The following is a description of a gene set: Mouse Gene Set: THEODOROU_MAMMARY_TUMORIGENESIS from publication Theodorou V, Kimm MA, Boer M, Wessels L, Theelen W, Jonkers J, Hilkens J (PMID 17468756) We performed a high-throughput retroviral insertional mutagenesis screen in mouse mammary tumor virus (MMTV)-induced mammary tumors and identified 33 common insertion sites, of which genes were previously not known to be associated with mammary cancer and 13 had not previously been linked to cancer in general. Although members of the Wnt and fibroblast growth factors (Fgf) families were frequently tagged, our exhaustive screening for MMTV insertion sites uncovered a new repertoire of candidate breast cancer oncogenes. We validated one of these genes, Rspo3, as an oncogene by overexpression in a p53-deficient mammary epithelial cell line. The human orthologs of the candidate oncogenes were frequently deregulated in human breast cancers and associated with several tumor parameters. Computational analysis of all MMTV-tagged genes uncovered specific gene families not previously associated with cancer and showed a significant overrepresentation of protein domains and signaling pathways mainly associated with development and growth factor signaling. Comparison of all tagged genes in MMTV and Moloney murine leukemia virus-induced malignancies showed that both viruses target mostly different genes that act predominantly in distinct pathways. Candidate mammary tumorigenesis genes from the common insertion sites (CIS) of MMTV virus that induced breast tumors in mice. studied in species Mus musculus, and this is the list of marker genes: Sfmbt2, Fgf4, Pdgfrb, Pros1, Nkd2, Gse1, Eras, Map3k8, Igf2, Atp2b1, Fgf6, Egr3, Rspo2, Foxc2 (NCBI Gene Id 14234), Jmjd1c, Notch4, Fgf10, Rspo3, Fgfr2, Astn2, Tenm1, Ptgis, Fgf3, Klf15, Dpp10, Agap1, Wnt1, Wnt3 (NCBI Gene Id 22415), Lamb1, Fgf8, Rreb1